Given this list of marker genes LRP12, ZNF92, TFR2, RIDA, TUSC1, UQCRB, CCDC150, FBXO32, TOP1MT, BUB1, DSCC1, BAZ2B-AS1, NAPRT, IFI16, TTTY2, FABP5, NSMAF, RAD21, SH3GLB1, SNAPC1, GLT8D2, NDUFB3, COQ10B, NEK1, HYCC1, A1BG-AS1, GALNT13, VPS13B (vacuolar protein sorting 13 homolog B), LINC02026, EFEMP1, NDUFS1, RANBP2, FGD4, MAP7, SNAPC5, BICRAL, SQLE (squalene epoxidase), RPS20, RAMP1, TMEM161B-DT, MTHFD1, C15orf32, PRKRA, NTAQ1, INSIG2, FSTL3, CHD1L, EEF1D, SCRIB, VIRMA, AGO2, GLA, SOBP, CHMP4C, COMMD5, INTS8, COL2A1, ZFTRAF1, LGALS3, MIR3142HG, PTGER2, MPI (NCBI Gene Id 4351), DTYMK, HSPA1A, NDUFB9, CCT6A, GNAL, VPS52, PHF20L1, TCF21, PPP1R7, CTHRC1, KIAA0586, JPH1, PWP1, RBM45, VPS28, EIF2AK1, NSD1, RPL8, SESTD1, PLAGL1, PNMA8A, C8orf76, PRPF40A, RSPO4, DHRS1, H2BC5, SLC39A4, BHLHE40, IL17B, NOL3, SSB, VEGFC, NUMB, RAN, FIGN, GPANK1, STK38, BZW1, POLR2L, SFT2D2, NR2C1, ENY2, PPIAL4A, IMPA1, CDH26, DERL1, THOC5, DCAF13, PLAG1, PCM1, MGARP, SYBU, MTUS1, EIF3H, TMED6, ASCC3, NSMCE2, UBXN8, ERBB4, UTP23, PSMC6 (proteasome 26S subunit, ATPase 6), NOL7, SMARCAL1, RPL7, PFKM, TRIP12, RNF139, ZNF736, SP6, HOXD4, DUXAP10, GSTP1, FAM111B, TTC28, INTS10, MRPL13, NUCKS1, MYBL1, IGLV4-60, ATAD2 (ATPase family AAA domain containing 2), EBAG9, GPR137C, XRCC5, SMUG1, NIPAL2, ECHDC2, STAT1, TTC23, FKBP11, MRPL15, TM2D2, MSMO1, PIGH, HSPE1, CSNK2B, IWS1, ASAH1, CACYBP, REC8, EIF4EBP2, ZNF114, NRBP2, MFNG, CYRIB, RDH10, ZNG1A, TERF1, PLIN2, AP3M2, PTPMT1, PTK2, SCRN1, ARMC1, COL4A4, ASB15, ETFB (electron transfer flavoprotein subunit beta), LRRC41, AMMECR1L, ACTR3, OR2L13, GS1-24F4.2, OSR2, NDUFAF6, TMEM74, PCBD1, MTHFS, COPS5, TRMT12, DUXAP9, FIS1, MAPK1IP1L, SF3B1, ELOC, here is a description of the gene set: species: Homo sapiens Murine Cytomegalovirus (MCMV) infection leads to early activation of various immune cells, including B and T lymphocytes, before the actual initiation of antigen-specific adaptive immunity. This activation is partly driven by innate cytokines, including type I interferon (IFN), which are induced early after infection. The objective of this study was to address the role of type I IFN in shaping early/innate B and T cell responses to a primary acute viral infection. In order to decipher the specific impact of IFN-I on cell subsets, we performed a genome-wide expression analysis on WT splenic B and CD8 T lymphocytes isolated from C57BL/6 mixed bone marrow chimera mice. This study complements series GSE39555, which focused on early responses of NK cells and of the two subsets of conventional dendritic cells. Human Gene Set: GSE45365_CTRL_VS_MCMV_INFECTION_NK_CELL_DN Genes down-regulated in NK cells: control versus acute primary viral infection.